The following is a description of a gene set: from publication Baek D, Villén J, Shin C, Camargo FD, Gygi SP, Bartel DP (PMID 18668037) This array analysis is to study developmental time course of the regulation of target messages’ expression during culture of murine neutrophils versus miR-223 null neutrophils. Culture media was SILAC-IMDM for MS analysis. Human Gene Set: GSE12003_4D_VS_8D_CULTURE_MIR223_KO_BM_PROGENITOR_DN Genes down-regulated in of bone marrow progenitors with MIR223 knockout: 4- versus 8-day cultures. studied in species Homo sapiens, and this is the list of marker genes: DERL3, NRG4, POC1B, TRAM2, MYBL2, OTUD5, TGFBR3, DNMT1, BCKDK, FYB1, TMC3, LPIN1, FAM234A, PDE3B, WIPI1, PITPNC1, SMAD3, SLC25A19, ADPRH, FSCB, PHF21A, TAX1BP1, DBI, MS4A1, TEX15 (testis expressed 15, meiosis and synapsis associated), RNF216, ICOS, SGMS1, HPCAL1, TICAM2, MPV17, CTDSP2, DTX3, SEPTIN10, NUDT22, SLC4A8, CDC25C, ETV6, B4GALT1, PSTPIP1, TTC9C, CDCA5, EXO1, RDH12, FBXO6, PTCH1, GRAMD2B, TMEM192, INSM1, GATM (glycine amidinotransferase), INTS9, LBH, LAMC1, UBE2R2, SMPDL3B (sphingomyelin phosphodiesterase acid like 3B), TLE4, SDCBP2, CD52, HAVCR2, HDHD5, PHYH, PANK4, ANKRD12 (ankyrin repeat domain 12), COTL1 (NCBI Gene Id 90755), MTCH1, CDK5R1, CEP85 (centrosomal protein 85), NOSIP, RFT1, PRKD2, KIF21B, STX5, ZER1, CCR6, FAM83D, TBC1D4, BEX3, TTLL12, TMEM43, AGR3, TCF19, FBXO8, SEPTIN1, DHCR7, MAD2L1, MFSD13A, GRHL1, CLIP1, NLRC3, RAD21, UBE2V1 (ubiquitin conjugating enzyme E2 V1), TRIP13, AIDA, ADAMTS10, LPP, SMOX, ZMAT5, PPIL1, NDUFS2, DGKZ, MVB12A, VAMP1, POU6F1, TMEM218, ARHGAP4, ABTB1, ANXA7, SH3BGRL, ACSF2, NCAPH, PPP6R2, TREML1, COG1, OSBPL3, TRAPPC1, CCN4, LAPTM5, LMNB1, FARP1, NXPE3, FANCG, ARSG, TMEM134, CMAHP, CDK19, CSRP1, ENDOD1, DDIT4, COMMD10, RGMB, CEP55, PADI4 (NCBI Gene Id 82795), IRS4, CYTH4, RNF214, CSNK2B, QSOX1, UBASH3A, CPD, PIK3C2A, MZT2B, VDR, BMPR1A, ACP5, TESC, GPR108, PKP3, VSIG10L, SPO11, IMPA2, ARID5A, CD79B, TBC1D22A, PTBP3, TRIM40, IFFO1, OPLAH, WDR62, PAX5, AHNAK, TBC1D9B, CTSA, PDLIM7, SYNJ2, CCDC163, BPNT1, DGKI, IDH2